The following is a description of a gene set: Any process that modulates the frequency, rate or extent of eating behavior. studied in species Homo sapiens Human Gene Set: GOBP_REGULATION_OF_EATING_BEHAVIOR, and this is the list of marker genes: NPSR1, NPY, NMU, TTC21B, GHSR, NAPEPLD, GHRL, MC4R, SLC24A4, OPRK1